The following is a description of a gene set: species: Homo sapiens Abnormality of visual evoked potentials Human Gene Set: HP_ABNORMALITY_OF_VISUAL_EVOKED_POTENTIALS An anomaly of visually evoked potentials (VEP), which are electrical potentials, initiated by brief visual stimuli, which are recorded from the scalp overlying the visual cortex., and this is the list of marker genes: SCAPER, GJC2, ARSA, TCIRG1, ITPR1, MT-ND6, MPDU1, PRPH2, MT-ND2, OSTM1, TNFSF11, CNGB3 (NCBI Gene Id 6021), POLG, MT-CO1, CWC27, PSAP, DNM1L, CLCN7, MT-ND4, ATP1A3, PROM1, MOGS (NCBI Gene Id 7841), SNF8, LAMA2, MECR, ERCC6 (ERCC excision repair 6, chromatin remodeling factor), MFN2, ABCA4, MT-ND4L, ELOVL4, MT-ATP6, PLA2G6, RAB3GAP2, ZNHIT3, NOTCH3, MT-ND5, CLN8, DNAJC30, CYP27A1, SPG11, PRPS1, SNX10, MT-ND1, ATXN1, MT-CO3, TIMM8A, POGZ, EMC1 (ER membrane protein complex subunit 1), ACOX1, NDRG1, TTPA, ARHGEF2, POMGNT1, SUCLA2, SLC25A22, UCHL1, AAAS, COX6B1, MFF, FXN, TYR, RAB18, NDUFS2, TBC1D20, RDH11, GALC, ERCC8, NDUFS4, OPA1, RAB3GAP1, MT-CYB